The following is a description of a gene set: Enables transmembrane transfer of calcium ions from an intracellular store to the cytosol on induction by increased calcium concentration. Human Gene Set: GOMF_CALCIUM_INDUCED_CALCIUM_RELEASE_ACTIVITY species: Homo sapiens, and this is the list of marker genes: RYR1, RYR2, BNIP1, RYR3, PKD2